The following is a description of a gene set: Genes predicted to be targets of miRBase v22 microRNA hsa-miR-4482-5p in miRDB v6.0 with MirTarget v4 prediction scores > 80 (high confidence targets). species: Homo sapiens from publication Chen Y, Wang X (PMID 31504780) Human Gene Set: MIR4482_5P, and this is the list of marker genes: CDH18, CLCN5, MKRN1, ANKRD34A, PBX1, ASIC1, ZNG1B, ANKH, ZC3HAV1, CFAP210, ZNG1A, ZNG1F, CCDC83, FCRL1, UPF1, ZNG1C, RALA, ATL1, KRTAP3-2, ACVRL1, ZMYM2, KANSL1L, CCNB1, ADCY1, EPHA7 (NCBI Gene Id 2045), MYCN, ZRANB1, OSBP, MRPL35, RAB14, ALG10, ZNG1E, LNPK, SCN1A, TAF7, CWC25, YAP1, VPS54, TCF7, SMARCE1, USF3, AKIRIN1